The following is a description of a gene set: Mouse Gene Set: MIR_7651_3P Genes predicted to be targets of miRBase v22 microRNA mmu_miR_7651_3p in miRDB v6.0 with MirTarget v4 prediction scores > 80 (high confidence targets). from publication Chen Y, Wang X (PMID 31504780) species: Mus musculus, and this is the list of marker genes: Amot, Brpf3, Crem, Zfhx3, Ahr, Zbtb37, Vps26b, Dzip3, Ccn4, Atp8b1, Samd13, Ankrd12, Rab10, 9330159F19Rik, Socs2, Nfxl1, Ctsc, Ppp4r3a, Uqcrh, Dtl, Slmap, Rev3l, Prag1, Gen1, Ergic2, Setd1b, Epc2, Lcn9, Scn1a, Igfbpl1, Scai, Eaf1, Sprr2a1, Hacd2, Pde7b (NCBI Gene Id 29863), Plod2, Scn2a, Magea2 (NCBI Gene Id 17138), Elovl2, Ebf2, Hecw2, Rabgap1l (RAB GTPase activating protein 1-like), Sart3, Zdhhc2, Prkcb, Cenpw, Sgip1, Cadm2, Nufip2, Huwe1, Foxo3, Lhfpl3, Ralgps2, Ints8, Orc4, Ino80d (NCBI Gene Id 329170), Ctsl, Gria2, Ago2, Septin8, Myh10, Tardbp, Afap1, Tmem161b (NCBI Gene Id 72745), Rnf144b, Gpt (glutamic pyruvic transaminase, soluble, NCBI Gene Id 76282), Rbpj, Plppr4, Zcchc24, Slco6d1, Atxn2, Camk1d, Zpbp2, Dcun1d1, Il13ra1, Eomes, St8sia3, Sinhcaf, Dusp8, Enpep, Scn3a, Rps19bp1, Pcsk1, Dnmt3a, Ercc8, Arf6, Ccdc28b, Phf20l1, Gpc6, C330018D20Rik, Slc2a2, Sorcs1, Pdc, Fam163a, Srgap3, Ttpal, Slain2, Gad2, Aebp2, Dennd5b, Sprr2a2, Sp4, Zic2, Stim2, Dach1, Pclo, Tmem229a, Mgat2, Vps13a, Sec24d, Plet1, Eya4, Ctnnal1, Kcmf1, Fut9, Nfx1, Mau2, Drg1, D430041D05Rik (NCBI Gene Id 77092), Nek5, Hnf1b, Kif1b, Fam13c, Metap1, Tdpoz9, Map10, Zfp455, Prkacb, Sdhc, Efcab14, Eif2ak3, Tmem196, Immt, Mmp24, Arpp19, Zfyve16, Csn3, Eif4g2, Slc66a2, Zyg11b, Bicd1, Zic3